Given this list of marker genes RPA1, UBA52, POLK, RPS27A, REV3L, REV1, RFC1, UBC, RPA3, RFC4, RFC5, RFC3, UBB, RPA2, MAD2L2, RFC2, PCNA, here is a description of the gene set: part of: Translesion synthesis by Y family DNA polymerases bypasses lesions on DNA template Reactome Pathway: Translesion synthesis by POLK species: Homo sapiens DNA polymerase kappa (POLK) is a Y family DNA polymerase that is most efficient in translesion DNA synthesis (TLS) across oxidation derivatives of DNA bases, such as thymine glycol (Tg) and 8-oxoguanine (OGUA), as well as bulky DNA adducts, such as benzo(a)pyrene diol epoxide guanine adduct (BPDE-G). POLK carries out TLS by forming a quaternary complex with REV1 and POLZ (REV3L:MAD2L2) at DNA damage sites, where POLK simultaneously binds REV1 and monoubiquitinated PCNA. POLK and POLZ cooperate in the elongation of nucleotides inserted opposite to lesioned bases by POLK. Similarly to POLZ, POLK has low processivity and is error-prone.